Given this list of marker genes DPH3, GTPBP3, ELP3, ELP2, ELP5, ALKBH8, TRMU, MOCS3, URM1, ALKBH1, ADAT2, ELP4, TRMT9B (tRNA methyltransferase 9B (putative)), NAT10, CTU2, NSUN3, KTI12, MTO1, ELP1, CTU1, ELP6, here is a description of the gene set: The process in which the nucleotide at position 34 in the anticodon of a tRNA is post-transcriptionally modified. Human Gene Set: GOBP_TRNA_WOBBLE_BASE_MODIFICATION studied in species Homo sapiens